The following is a description of a gene set: from publication Fu W, Ergun A, Lu T, Hill JA, Haxhinasto S, Fassett MS, Gazit R, Adoro S, Glimcher L, Chan S, Kastner P, Rossi D, Collins JJ, Mathis D, Benoist C (PMID 22961053) The transcription factor FoxP3 partakes dominantly in the specification and function of FoxP3+ CD4+ T regulatory cells (Tregs), but is neither strictly necessary nor sufficient to determine the characteristic Treg transcriptional signature. Computational network inference and experimental testing assessed the contribution of several other transcription factors (TFs). Enforced expression of Helios or Xbp1 elicited specific signatures, but Eos, Irf4, Satb1, Lef1 and Gata1 elicited exactly the same outcome, synergizing with FoxP3 to activate most of the Treg signature, including key TFs, and enhancing FoxP3 occupancy at its genomic targets. Conversely, the Treg signature was robust to inactivation of any single cofactor. A redundant genetic switch thus locks-in the Treg phenotype, a model which accounts for several aspects of Treg physiology, differentiation and stability. Genes down-regulated in CD4 T conv: control versus over-expression of SATB1. species: Homo sapiens Human Gene Set: GSE40274_CTRL_VS_SATB1_TRANSDUCED_ACTIVATED_CD4_TCELL_DN, and this is the list of marker genes: NUP43, RRP12, MPHOSPH10, LSG1, NDUFB4, VAMP3, TIPRL, TAF9, NLE1, SMOX (spermine oxidase), SINHCAF, GCLC, BOP1, EIF2S1 (NCBI Gene Id 1965), JOSD1, SOX7, KLHL21, YARS1, REEP6, SMARCA5, PISD, FRS3, BEX3, DKC1, CMTR2, MIR23B, ST6GALNAC4, TFDP1, SPIN1, KCNC3, TRMT6, SNORD73A, TLCD1, PLK3, UFM1, PRPS1L1, MARCKS, PMPCA, DNMT3B, HMX3, DLK1 (delta like non-canonical Notch ligand 1), MYBBP1A, CCT4, NME2, ECE2, MAFK (NCBI Gene Id 7975), UCK2, PPP1R16B, NAB2, CITED4, USP1 (ubiquitin specific peptidase 1), IFIT1, ICOS, PSMD7, SRXN1, CCR7, ERO1A, MED9, DGAT2, XPOT, DNAJB6, WDR12, P3H1, SMAD6, CCDC85C, IL10, IGLON5, COQ8A, TENT4A, NUP133, SMARCC1 (SWI/SNF related, matrix associated, actin dependent regulator of chromatin subfamily c member 1), UCHL5, SLC25A26 (solute carrier family 25 member 26), RBBP8, BATF, SNRPD1, TBC1D15, OTULIN, GOLM2, MRPS18B, TRUB2, SLC3A2 (solute carrier family 3 member 2), PSKH1, PUF60, CDV3, POLR1B, IDE, SIK3, NR1D2, EHD1, BCL2L11 (BCL2 like 11), GOT1, RARS1, NUDC, NIBAN2, PLCL2, AOC2, GART, GCN1, WDR46, RIPK2, SNU13, NR2E1, NRIP3, YRDC (NCBI Gene Id 79693), PRMT3, POU4F1, CBX1, ADAT2, LRRC8D, TBL2, PVT1, PSAT1, TRNAU1AP, SURF2, TMEM17, MAPKAPK3, SLC35F2, NT5C1B, EIF4A1, BHLHE22, BAMBI, JADE3, NRARP, LARP1, EFTUD2, TBL3, PSMA3, UBE2O, ATP7B, NARS1, IGF2BP3, RNF26, STXBP1, BHLHE40, ARF5, PMP22, B4GALT5, SAXO1, BTBD9 (BTB domain containing 9), UMPS, PDCD5, MATR3, TUBB2A, PTPRS, IL1A, JTB, PSME3, MED10, DUSP3, NAF1, GPR84, TAGAP, FOSB, QTRT2, SLC39A14, CDK6, ADO, RANBP2, DUS4L, GFPT1, SNRPA1, PSMB5, PPP4R2, RYBP, PSMC2, SLC2A6, TRIM37, CENPB, MARS1, MESD, JAGN1